Given this list of marker genes SMC3, SMC1B, STAG2, SMC1A, SGO2, RAD21L1, RAD21, STAG1, STAG3, DDX11, REC8, here is a description of the gene set: species: Homo sapiens Human Gene Set: GOCC_COHESIN_COMPLEX A protein complex that is required for sister chromatid cohesion in eukaryotes. The cohesin complex forms a molecular ring complex, and is composed of structural maintenance of chromosomes (SMC) and kleisin proteins. For example, in yeast, the complex is composed of the SMC proteins Smc1p and Smc3p, and the kleisin protein Scc1p. In vertebrates, the complex is composed of the SMC1 (SMC1A or SMC1B) and SMC3 heterodimer attached via their hinge domains to a kleisin (RAD21, REC8 or RAD21L) which links them, and one STAG protein (STAG1, STAG2 or STAG3).